The following is a description of a gene set: from publication Chen Y, Wang X (PMID 31504780) Human Gene Set: MIR9985 Genes predicted to be targets of miRBase v22 microRNA hsa-miR-9985 in miRDB v6.0 with MirTarget v4 prediction scores > 80 (high confidence targets). species: Homo sapiens, and this is the list of marker genes: FOXP4, KMT2C, ZSCAN26, SLC35F4, RBPMS2 (RNA binding protein, mRNA processing factor 2), PDE7B, MYH10, SFRP1, GAB1, TMEM184A, PRKCB, STYK1, COLGALT2, SPRY2, ZFHX3, SCAF11, ENOX1, NRARP, APPBP2, HAPLN1, AMD1, SLC24A4, PDIA5, EN2, ARRDC4, ARF3, TTC39A, VAPB, CCDC28B, OAF, ADCY6, HIPK2, ZNF84, C11orf58, PTGDR, ABHD17C, RELN, SLC24A1, KCNJ3, EDAR, LCOR, POGLUT1, SLC35F1, CDR2, COG7, YWHAB, GPAM, SEH1L, MIER2, BRPF3, MIGA2, ITSN2, RGL2, NCAM1, SLC25A16, FAM184A, UBE2V1, FAM76B, HSDL1, KMT5A (NCBI Gene Id 387893, lysine methyltransferase 5A), TRPV3, NXF1, SYNRG, CKAP4, CDH5, NCOA5, BTG2, VAV3, RGS8, ROR1, CSF1, CDC42EP3, PLCL2, PAIP2B, MED14, FCRL1, FZD4, AQP11, OGA, DCP1A, CA10, PPP4R2, ABHD6, CHKA, CAMTA1, GRIA4, MDN1, ZNF329, INSM2, PDHX, NR5A2, FLRT3, TRERF1, DCUN1D4, TMEM170A, RNF139, WBP1L, GALNT7, HSPH1, NDUFS4, ARFGEF1 (ADP ribosylation factor guanine nucleotide exchange factor 1), ST3GAL6, INSR, EDRF1, LYSMD3, WDCP, RCAN2, TEAD1, SOX7, STAB2, CSRP2, PLEKHJ1, POU3F2, FGF7, ST6GALNAC3, BNIP2, CCN4, CACNA2D3, TICRR, UNC13C, SS18L1, SCAI, KCTD14, GEM, SEMA7A, OTX2, MED12L, SRL, SERBP1, CELF2, GFPT2, CALD1, NUP210, PLPPR1, MDM4, PNISR, UNKL, PARD6B, KDM3A, TBR1, RYBP, SEC62, RGPD6 (RANBP2 like and GRIP domain containing 6), FOSB, GOLGA1, RASSF3, PRKX, MKLN1, STX16, FRMD6, CLCN3, KCNK5, TNPO1, ZFP36, SLC13A3, EPS8, PSPC1, AFF4, PRKG1, B4GALT3, PSMA1, SLC46A3, INPP5J, STK39, TSPYL1, CTH, ARMC8, EHF, MRPS14, CDIP1, RCOR3, ZNF608, INPP1, ATP11C, ZMYM4, HIVEP3, CREB1, ARHGEF7, FOXO3, AKIRIN1, NR2C2, PLEKHH1, EIF5A2, NR3C1, ABITRAM, ZFAND3, DOT1L, FAM133B, DCAF12, CLK2, WSB1, NXT2, ANKRD40, NETO1, SEMA6D, RPS6KA5, DKK2, NRBF2, TRAF3IP3, PLAG1, TRIM50, CCNK, ABL2, ZMAT3, SBF2, SNX10, BEST1, PAQR9 (NCBI Gene Id 344838), HSPD1, AMPD3, FUBP3, SH3GL3, TMEM170B, MOCS3, CRACDL, YWHAQ, FBXO34, IPMK, TRAPPC8, NIPAL4, COPZ1, PEDS1-UBE2V1, ZCCHC24, CDK18, CDH11, SETD5, PANK1, FRS3, ADAMTS10, MMD, AFAP1, TMEM9B, UGCG, MARK1, CLSTN2, AK4, BMP3, MAP1B, TGFBR3 (transforming growth factor beta receptor 3), RMND5A, QKI, TOM1L1, TMA7 (translation machinery associated 7 homolog), RARA, ANKS1A, HDHD2, UNC5D, CAND1, USP42, CHD7, ERICH3, LOX, DYRK1A, NREP, TLK2, APOOL, ANK1, ENSG00000275993, RCBTB1, TXLNG, BNIP3 (BCL2 interacting protein 3), ARHGEF26, GATA6, TRAF3, HYCC1, LIMK1, USP31, COLEC10, RO60, KLF3, RALGAPA2, SHC4, PPARG, PIK3CA, PPP1CC, USF3, PHLPP2, TNRC6B, CTU1, USP46, NRP2, SRGAP2, PDPK1, COMMD3-BMI1, PRR3, SMAD9, PDE10A, E2F7, NPEPPS, SLC9A7 (solute carrier family 9 member A7), GRM5, PRLR, PRMT8, FBLN5, GLRA2, TPR, GATAD2A, MAP2K4, PAX9, EDEM3, KCTD8, FBXO10, GNS, HOXC6, RGPD8, BEND4, TMEM91, NEMP2, DCAF7 (NCBI Gene Id 10238, DDB1 and CUL4 associated factor 7), DYNLL2, PF4V1, ARL4C, RGPD4, PEAK1, RAPH1, EPB41L4A, SOWAHA, AHSA2P, GPT2, ACTA2 (actin alpha 2, smooth muscle), BICC1, RNF141, UBE2N, INO80D, GATA3, TOR2A, PCDH9, ASAH1, KAT2B, SHE (Src homology 2 domain containing E), LIFR, PF4, DNAJC13, SMOC2, NRK, KCMF1, C1orf52, GAREM1, CCNG1, TCIM, NEURL1B, HEG1, DYNC2LI1 (NCBI Gene Id 51626), CNN3, KITLG, ELFN2, PCLO, PLCH1, ING5, COL21A1, STMN2, GOLM1, ASPH, KHSRP, SMAD5, NF1, TAB3, CCNT2, ST14, SLC5A7, ADORA2B, WIPF2, NCOA7, ABCA1, MIER3, ADAMTSL3, RAB11FIP1, ZBTB39, FN1, PKIA, SRP19, ITGA5, STAC, MAPK14, WNK3, WDR37, CCNY, PATZ1, DNAAF9, ZNF708, ITGA8, ZNF268, PNPLA7, SYNJ1, ATAD2B, SLFN5, AKIRIN2, RIPOR2, RREB1, CEMIP, PNKD, MSL1, ELAVL2, CPPED1, DEPDC4, GPR6, KPNB1, CACNG2, ARHGAP32, NPTN, MYT1, SLC22A23, TAF5L, MBTD1, FOXO1, RC3H1, GRIN2D, HIP1, FAM78A, SLC35A3, MAP2K7, MTURN, GPD2, BRWD3, KPNA3, SNRNP27, KIAA0319L, SORL1, SLC16A10, FAM217B, ERG, TMPRSS7, KCNA4, PAIP2, FBXO45, VAV2, XPO1, GRIA3, GXYLT1, MTMR4, SLIT2, TRIL, SLC9B1, NCALD, SOX11, PELI2, BTG1, TSC1, INA, SPTLC2, BLTP3A, AGRN, SNAP25, REPS1, VSIG10, HOXA10 (homeobox A10), NECAB1, PPIF, PSEN1, CCM2, MTARC1, GLTP, GCC2, COL19A1, UBR5, CMKLR1, ZBTB20, KCNK2, CAMK1D, NSD1, EYA4, LONRF1, EEF1AKMT4-ECE2, MTCL2, SPATA13, ALDH5A1, C2CD2 (C2 calcium dependent domain containing 2), MAP3K4, NKAIN1, RUNX1, TMBIM6, EGFR, DNAJC27, RNF8, TMCC1 (transmembrane and coiled-coil domain family 1), SLC7A11, PTGER3, DDX5, ZNF800, HS2ST1, STAG1, AGFG1, NR2F6, NR1D2, CDS1, FCRL2, SCN1A, NR2F2, TNRC18, SUCO, NPAS3, RNF38, ACVR1C, KDM7A, POU2F3, ECE2, EPB41, MATN3, SIX1, FAM171A1, TSC22D2, ZIC5, ID4, SLC9A4, HYOU1, SLCO5A1, RNGTT, ONECUT2, CCNJ, THRB, KLHL31, NAV2, OTULIN, HBEGF, GATC, RSBN1L, ZHX1, NHLH2, PLEKHA5, SEMA6A, ABHD17B, KBTBD8, CIPC, SLITRK1, KLHL29, IRF4, PDE3B, PEG10, LITAF, NECAP1, EYA1, RSPO3, FBXW7, GNG12, RAPGEF2, CREBRF, NABP1, BEX3, SLC7A2, NEK6, SOS1 (SOS Ras/Rac guanine nucleotide exchange factor 1), MGAT4A (alpha-1,3-mannosyl-glycoprotein 4-beta-N-acetylglucosaminyltransferase A), RPGRIP1L, RAP2A, RGPD5, LPAR6, USP25, BLTP1, SLC6A1, MS4A7, MKNK2, ZDHHC17, TFAP2B, ZNF705EP, ZBTB34, SMAD4, LARP4, HIC1, B3GNT7, ABCB9, GRB2, TAPT1 (transmembrane anterior posterior transformation 1), SZRD1, GALNT3, DLL4, SFSWAP, RPN2 (NCBI Gene Id 6185), NDUFC2-KCTD14 (NDUFC2-KCTD14 readthrough), SLC25A25, NEURL4, KCNN3, CYP39A1 (NCBI Gene Id 51302), NGFR, DTNA, SLC30A7, DIPK1A, CCNC, HOXA5, TERB2, NEDD4, RUFY3, PLK2, HSD17B12, SLC39A11, ZNF80, GATA2, ARX, RPS6KB1, EFNB2, PLPP3, CECR2, ATP2B1, PHB1, IKZF2, FOXA3, PDS5B, CAPN15, ADGRA3, SSH1, TRIM23, NOVA1, GRAMD1B, PALM2AKAP2, CEP135, ZNF426, SATB2, HMGCR, GSPT1, LPCAT1, MAGI3, SNN, KMT5B, PCNX1 (NCBI Gene Id 23690), PDK4, PLXND1, PTCH1, LIPT2, TET1, LPIN1 (NCBI Gene Id 23175), SIK1, ADAMTSL1, ATP1A2, ENDOU